The following is a description of a gene set: studied in species Homo sapiens Human Gene Set: HP_ABDOMINAL_SITUS_INVERSUS A left-right reversal (or mirror reflection) of the anatomical location of the viscera of the abdomen. Abdominal situs inversus, and this is the list of marker genes: PIGG, NSD2, LETM1, CTBP1, CFAP53, CFC1, CPLX1, CLXN, NELFA, ACTG2, FOXJ1, DAW1, CHD6, PKD1L1, NODAL, CFAP52, ZIC3, TBX5, CCDC32